The following is a description of a gene set: Human Gene Set: REACTOME_COHESIN_LOADING_ONTO_CHROMATIN species: Homo sapiens Cohesin Loading onto Chromatin, and this is the list of marker genes: STAG1 (NCBI Gene Id 10274), MAU2, STAG2, PDS5A, SMC1A, NIPBL, WAPL, SMC3, RAD21, PDS5B